Given this list of marker genes SPTAN1, PDLIM1, AGO1, ZNF154, KLC1, SORT1 (NCBI Gene Id 6272), CLDN14, PLPP2, CCL5, TTLL7, NPAS1, IL13RA2, MCRS1, CYP2U1, LAMB3, SYNPO, RBM5, CATSPERB, CLIC1, CRIP1, TUB, GADD45G, SLCO4A1, NR2C1, SLC22A13, NODAL, AIM2, PHLPP2, CORO7, BRPF1, DEPDC1, TRGV5, HMGXB3, SLC12A2, ZNF767P, CLSTN2, JMJD4, ARHGAP17, VSTM4, MRPL39, GLI3, KIAA0753, SETD3, YTHDC2, OR3A1, SOX21, PSG7, ASB9 (NCBI Gene Id 79067), PAK3 (p21 (RAC1) activated kinase 3), ZFR, RC3H2, OMP, PMM2, RPS19, ZNF80, TOM1L1, DDX39B, ANK1, FAAP100, DDT, F2RL3, TIMP4, ANKRD7, RPH3AL, LST1, MYRIP, FGGY (FGGY carbohydrate kinase domain containing), ZNF205, MAP3K5, SEMA3C, PCGF3, FCER2, ALPL, SLC2A2, SLC17A9, CPNE7 (copine 7), MYCL (MYCL proto-oncogene, bHLH transcription factor), TNIP1, GUCY1A1, HSF2BP, TAFAZZIN, GALR1, ARHGAP25, VWA7, DDIT4, CASP9, PPRC1, NIPA2, VIP, FBXL6, TCP11, FBLN1, WDR1, GPR87, FGFR3, CBX6, PNPLA6, DSTYK, ELMO3, POU3F4, CMC4, ALCAM, MYH14, DIPK1A, TRO, OGFR, ZNF292, SERPINE2, PKD1P6, SLC5A3, SCAF8, RPL13A, RNPEPL1, RNASEH2B, LBH, FXYD5, STAG3, SMG6, TFG, PTPN7, FAN1, HSD17B3, ZNF157, HMBOX1, CDC42BPB, LOXL2, VPS37B, DTX3, BMPR1B, FABP4, KLHL11 (NCBI Gene Id 55175), PPP6R2, SLC38A4, GPI (glucose-6-phosphate isomerase), SCO2, NCS1, ZMAT3, PKD1P1, IPO13, CDKAL1, PPP1R16B (NCBI Gene Id 26051), ZBTB39, APOM, SVIL, SCN3A, RABGAP1, PKNOX2, F10, KLK10, NOL3, PPFIA2, ZNF654, SACS, KPNA4, TFE3, SPEN, CSPP1, RFTN1, RRAS2, ZFHX4, RNF123, KCNK10, CEP170B, RPS13, SNCG, HOXB8, KMT2D, HHLA2 (NCBI Gene Id 11148), TSPAN9, GREM2, RELB, GAS2 (growth arrest specific 2), STATH, C2, EFHD2, METTL1, SPG7, GUSBP14, RAPGEFL1, SH2D2A, ICOSLG, LRRC17, SLC4A2, SH2D4A, NUDT3, KCNV1, WLS, MYG1, ERBB2, NXF1, SYN2, MYOD1, PLIN1, ARF6, ATR, here is a description of the gene set: In order to identify the molecular mechanisms of PPARgamma phosphorylation at Set273, we generated cell-lines of PPARgamma KO MEFs expressing wtPPARgamma or S273APPARgamma. In addition, because our data showed that PPARgamma ligand drugs such as rosiglitazone and MRL24 blocked this phopshorylation, we treated cells with these drugs, then prepared RNA samples to look at the gene profiling. Human Gene Set: GSE22033_WT_VS_PPARG_KO_MEF_UP species: Homo sapiens Genes up-regulated in mouse embryonic fibroblasts (MEF): wildtype versus PPARG knockout. from publication Choi JH, Banks AS, Estall JL, Kajimura S, Boström P, Laznik D, Ruas JL, Chalmers MJ, Kamenecka TM, Blüher M, Griffin PR, Spiegelman BM (PMID 20651683)